Given this list of marker genes Hipk2, Zic2, Traf2, Esr1 (NCBI Gene Id 13982), Prdx3, Tnfrsf11a, Wnt3a, Ar, Hmgn3, Traf6, Ikbke, Npm1, Tirap, Wnt5a, Trim30c, Rps3, Bud31, Prkcz, Bcl10, Tlr2, Nkx3-1, Mtpn (NCBI Gene Id 319218), Zbtb7a, Ddit3, Cd200, Rhebl1, Trim8, Il1b, Tssk4, Rgcc, Rnf31, Ankrd42, Ep300, Ticam1, Cflar, Cd40lg, Reln, Irak2, Phb2, Trim30a, Pten, Crnn, Tnfsf18, Ltf, Clu, Crtc3, Psma6, Cd40, Trim15, Trim30b, Nts, Arhgef5, Dhx9, Trim12c, Cat, Rnf220, Fank1, Trim14, Trim13, Ppia, Aim2, Trim37, Rab7b, Clock, Lrrfip2, Smarca4, Cops5, Card9, Cth, Lpar5, Ripk4, Il18r1, Ager, Fzd2, Camk1d, Myocd, Trim25, Trim12a, Dhx33, Ntrk1, Tlr3, Esr2, Camk2a, Ripk3, Map3k13, Smarcb1, Ins2 (NCBI Gene Id 16334), Hsf1 (heat shock factor 1), Adcy8, Srf, Ror1, Thap11, Prkd1, Atf2, Pparg, Trim32, Malt1, Ppp2r5b, Erc1, Crtc1, Prkd2, Ppargc1a, Irak3, Ifrd1, Neurod1, Il18, Tnfsf11, Jup, Prkch, Mid2, Tcf3, Hdac2, Eif2ak2, Il4, Bdnf, Crebbp (NCBI Gene Id 547230), Kit, Fcgr2b, Grem1, Prkcq, Tnf, Nlrc4, Tgfbr3, Fzd1, Il18rap, Cytl1, Adgrf1, Ripk1, Rps6ka5, Myd88 (myeloid differentiation primary response gene 88), Csrp3, Sphk1, Traf5, Wnt2, Fzd4, Ins1, Epha5, Lrp6, Rnf25, Arid5b, Trim5, Il6 (interleukin 6), Nod2, Rbck1, Pycard, Edn1, Terf2ip, Plpp3, Card14, Neurod2, Ddrgk1, Trim27, Hdac5, Ppp3ca, Trim31 (tripartite motif-containing 31), Arhgef2, Traf1 (TNF receptor-associated factor 1), Nodal, Zc4h2, Nlrp3, Cd84, Hdac4, Park7, Crtc2, Lamtor5, Rwdd1, Slco3a1, Trim38 (NCBI Gene Id 214158), Trim62, Tlr4, Il5, Capn3, Foxa1 (NCBI Gene Id 15375), Adcy1, Akt1, Lrrfip1, Trim30d, Ikbkg, Carm1, Tfrc, Fer, Neurog1, Sp100, Bex2, Trim21, Rtkn2, Nod1, Il10, Neurog2, Dvl2 (dishevelled segment polarity protein 2), Trappc9, Anxa3, Il1rap, Cib1, Ripk2, Sting1, Trim52 (tripartite motif-containing 52), Prkci, Ddr2, Ikbkb, Irak1, Ube2n, Mavs, Card11, Mtdh, Bmp2, Rela, Ngf, Trim26 (tripartite motif-containing 26), Hspa1b, Wnt10b, here is a description of the gene set: Any process that activates or increases the frequency, rate or extent of activity of a transcription factor, any factor involved in the initiation or regulation of transcription. studied in species Mus musculus Mouse Gene Set: GOBP_POSITIVE_REGULATION_OF_DNA_BINDING_TRANSCRIPTION_FACTOR_ACTIVITY